The following is a description of a gene set: Reactome Pathway: Phase 3 - rapid repolarisation electronically inferred by orthology from the curated human pathway studied in species Mus musculus This event has been computationally inferred from an event that has been demonstrated in another species.<p>The inference is based on the homology mapping from PANTHER. Briefly, reactions for which all involved PhysicalEntities (in input, output and catalyst) have a mapped orthologue/paralogue (for complexes at least 75% of components must have a mapping) are inferred to the other species. part of: Cardiac conduction, and this is the list of marker genes: Kcne5, Kcnh2